Given this list of marker genes Gm19102, Gm15596, Gm13898, Tes, Gm13899, Gm18482, Gm23960, Tfec, Wnt2, Cftr, 4930524B17Rik, Gm15581, Mir6370, Gm15595 (NCBI Gene Id 100417564), Met, Asz1 (ankyrin repeat, SAM and basic leucine zipper domain containing 1), St7, Capza2, Gm6655, Cav1, Gm5874, Gm36669, Gm20186, Kcnd2, Eif3s6-ps4, Cttnbp2 (cortactin binding protein 2), Cav2, Gm15473, Lsm8, D830026I12Rik, Gm26373, Gm4876, Gm5721, Gm22828, Gm15593, Ankrd7, here is a description of the gene set: Mouse Gene Set: chr6A2 studied in species Mus musculus